The following is a description of a gene set: Genes predicted to be targets of miRBase v22 microRNA mmu_miR_7667_5p in miRDB v6.0 with MirTarget v4 prediction scores > 80 (high confidence targets). species: Mus musculus Mouse Gene Set: MIR_7667_5P from publication Chen Y, Wang X (PMID 31504780), and this is the list of marker genes: Rap2c, Adcyap1, Sv2b, Zc3h12d, Dgkb, Akap8, Accsl, Gpr161, Iqcd, Sgtb, Kcnv2, Elavl3, Pcbp3, Ap1s2, Mfsd1, Gabarapl2, Pdgfra, Stard13, Cd34, Cfap20dc, Slc7a3, Amot, Slitrk1, Ctbp2, Gucd1, Pde4dip, D17H6S56E-5, Cntn3, Zfand4, Srsf11, Cntnap2, Ubqlnl, Ube2q1, Atp1a1, Ube2g1, Lamp3, Ckb, Azin1, Ino80d, Klrd1, Ptprk, Tnip3, Armc7